Given this list of marker genes ADA, CCDC140, MLF1, UBE2L6, DPEP1, POGLUT3, GRTP1, NPC1L1, LINC01618, SPATA46, CFB, IFFO2, CSRNP1, CRLF2, EN1, OTUD1, SLC25A28, NEK11, TTLL10, BMPER, SHBG, COL4A6, NEUROD1, OASL, HS3ST3B1, MGC4859, CDIPTOSP, ADAMTS20, BTN2A3P, FAM43A, ZNF599, CITED2, EGR3, TMPRSS6, NOCT, GUSBP5, TRIM26, MIA3, OR8D1, AIM2, LCT, PLEKHA6, RFESD (Rieske Fe-S domain containing), GBP5, LINC01566, LYSMD2 (NCBI Gene Id 256586), COLEC11, TNIP3, CXCL11, COL4A2, GBX1, SHROOM4, ANKRD55, SNCAIP, CLEC5A, ADAMTS15, ZC3HAV1, OTX2-AS1, LSAMP-AS1, PARD3, CAMK1G, IFIT3, GPX8, OSR2, NIBAN3, ISG20, TSHB, KIF23-AS1, TLCD3A, ACTR3C, SYCP1, INHBA, IL1A, FAM171B, ZNF804B (NCBI Gene Id 219578), ACOD1, IFIT2, ATP13A3-DT, CFAP157, IFNB1, ZNF718, ESM1, PJVK, MKS1, CCNE2, TSC22D1-AS1, NMBR, HRH2, TEX12, FOXD2-AS1, IFNL1, HERC6, ERICH1, TENT4A, ESRRG, STUM, GCH1, CYB5D2, EOLA1-DT, GBP1, TRIML1, CH25H, OLIG1, REC114, DNAJC9-AS1 (DNAJC9 and MRPS16 antisense RNA 1), HCAR3, HERC5, MILIP, MBNL1 (NCBI Gene Id 9850), C21orf91, MICAL3, ANKS3, ATXN7L1, RNF149, PLEKHF2, OR6B1, DDX60, TRIM22, IFIT1, ZNFX1, CHPF, TGM5, ANKRD45, TGM4, FOXI1, RBP3, ZNF225-AS1, AAAS, BLVRA, PRDM1, IL10, MIR155HG, EGR1, NBN, JAG1, ZNG1A (NCBI Gene Id 57397), KRT13, IFIH1, SLC22A24 (solute carrier family 22 member 24), PPBP, DEFA6, TNFSF8, PPP1R15A, LZTS3, PSG11, PRMT7, WIF1, LAP3, CA5A, SNORD89, PIK3AP1, LINC02693, KLF4, GFRA4, CACNB3, TTLL2, PTX3, CDC45, HES4, CTTN, CECR9, PTGS2, SELENOK, MINDY1, VCPIP1, TLX3, EMD, TOM1L1, DOK6, GBP2, ENSG00000261327, HLF, IFI44, RHOB, GOLGA6L2, RNASE11, TSPEAR, LINC00221, PELI1, IL1B, DNAJB4, LCP2, RAB12, ISG15, NOL4L, PMAIP1, here is a description of the gene set: Human Gene Set: GSE2706_R848_VS_LPS_2H_STIM_DC_DN Toll like receptors (TLRs) sense microbial products and initiate adaptive immune responses by activating dendritic cells (DCs). Since pathogens may contain several agonists we asked whether different TLRs may synergize in DC activation. We report that in human and mouse DC TLR3 or TLR4 potently synergize with TLR7, TLR8 or TLR9 in the induction of selected cytokine genes. Upon synergistic stimulation, IL-12, IL-23 and Delta-4 are induced at levels 50-100 fold higher than those induced by optimal concentrations of single agonists, leading to enhanced and sustained TH1 polarizing capacity. Using microarray analysis we show that only 1.5% of the transcripts induced by single TLR agonists are synergistically regulated by combinations of TLR4 and TLR8 agonists. These results identify a combinatorial code by which DCs discriminate pathogens and provide (suggest) a rationale to design adjuvants for TH1 responses. Series_overall_design: 3 untreated, 3 treated with LPS at 2h, 3 treated with LPS at 8h, 3 treated with R848 at 2h, 3 treated with R848 at 8h, 3 treated with LPS + R848 at 2h, 3 treated with LPS + R848 at 8h Genes down-regulated in comparison of dendritic cells (DC) stimulated with R848 at 2 h versus DCs stimulated with LPS (TLR4 agonist) for 2 h. from publication Napolitani G, Rinaldi A, Bertoni F, Sallusto F, Lanzavecchia A (PMID 15995707) studied in species Homo sapiens